Given this list of marker genes Zc3h4, Exosc10, Srrt, Zc3h18, Rbm27, Papolg, Wdr82, Zcchc8, Mtrex, Zfc3h1, here is a description of the gene set: electronically inferred by orthology from the curated human pathway This event has been computationally inferred from an event that has been demonstrated in another species.<p>The inference is based on the homology mapping from PANTHER. Briefly, reactions for which all involved PhysicalEntities (in input, output and catalyst) have a mapped orthologue/paralogue (for complexes at least 75% of components must have a mapping) are inferred to the other species. species: Mus musculus Reactome Pathway: Nuclear RNA decay part of: Metabolism of RNA